Given this list of marker genes MARCHF6, TRAF6, UBE2V1, TRIM72, ZMYM2, PPARA, SIAH3, PARK7, ARIH1, RNF14, RNF19B, ARIH2, DCUN1D5, DCUN1D2, UBA2, RNF5, PRKN, RNF19A, RNF217, GRIK2, TCERG1, SIAH2, DCUN1D1, FOXL2, RNF144A, RPS3, DCUN1D3, DCUN1D4, AUP1, RNF185, TOLLIP, SIAH1, MARCHF7, UBE3D, RNF144B, ANKIB1, RNF125, RNF180, here is a description of the gene set: species: Homo sapiens Binding to a ubiquitin-like protein conjugating enzyme such as ubiquitin conjugating enzyme. Human Gene Set: GOMF_UBIQUITIN_LIKE_PROTEIN_CONJUGATING_ENZYME_BINDING